The following is a description of a gene set: Mouse Gene Set: GOBP_NEGATIVE_REGULATION_OF_FIBROBLAST_PROLIFERATION species: Mus musculus Any process that stops, prevents, or reduces the frequency, rate or extent of multiplication or reproduction of fibroblast cells., and this is the list of marker genes: Pawr, Nupr1, Fbxo4, Ifng, Cdc73, Fth1, Bmyc, Emd, Smarca2, Trp53inp1, Dab2ip, Ing5, Pparg, Men1, Sod2, Bax, Lta, Pmaip1, Med25, Cd300a, Ptprv, Inca1, Gstp1, Dach1, Myc, Ifi30, B4galt7, Med31, Trim32, Pex2 (NCBI Gene Id 52109), Trp53, Nlrc3 (NCBI Gene Id 268857), Ski, Kmt2a, Tsc2, Sfrp1, Kcnn4, Cav1, C1ql4, Morc3, Mmp9, Parp10, Lzts2, Agtr2, Nf1, Socs1